Given this list of marker genes Gdpd3, Gdpd1, Napepld, Naaa, Gde1, Abhd4, here is a description of the gene set: Mouse Gene Set: GOBP_N_ACYLETHANOLAMINE_METABOLIC_PROCESS species: Mus musculus The chemical reactions and pathways involving N-acylethanolamines. An N-acylethanolamine is an ethanolamine substituted at nitrogen by an acyl group.